The following is a description of a gene set: The removal of tubulin heterodimers from one or both ends of a microtubule. species: Mus musculus Mouse Gene Set: GOBP_MICROTUBULE_DEPOLYMERIZATION, and this is the list of marker genes: Fgf13, Mid1, Kif14, Map6d1, Ttbk2 (tau tubulin kinase 2), Camsap2, Apc, Map1b, Gas2l1, Cib1, Camsap1, Smn1 (survival motor neuron 1), Eml4, Kif18b (kinesin family member 18B), Camsap3, Clasp1, Kif2b, Taok1, Stmn1, Arhgef2, Atxn7, Kif2c, Kif19a, Clasp2, Rp1, Tpx2, Ccdc88c, Spef1, Spast, Gas2l2, Kif21a, Stmn2, Kif18a, Bbof1, Apc2, Trim54, Arhgef1, Kif24, Specc1l (NCBI Gene Id 75003), Nckap5l, Hdac6, Wdr47 (WD repeat domain 47), Htr1a, Aurkb, Nedd1, Htt, Map1s, Bmerb1, Nckap5, Ckap2, Katnb1, Mid1ip1, Trpv4, Hdgfl3, Map1a, Diaph3, Map2, Ccn2, Rhoa, Ccsap, Stmn4, Stmn3, Nav3, Sgk1